The following is a description of a gene set: from publication Chen Y, Wang X (PMID 31504780) studied in species Mus musculus Mouse Gene Set: MIR_6925_5P Genes predicted to be targets of miRBase v22 microRNA mmu_miR_6925_5p in miRDB v6.0 with MirTarget v4 prediction scores > 80 (high confidence targets)., and this is the list of marker genes: Sec22c, Mup18, Hoxc4 (NCBI Gene Id 15423), Cpeb4 (NCBI Gene Id 67579), Atxn1l, Iqcm, Mup12, Tfcp2l1, Galnt3 (polypeptide N-acetylgalactosaminyltransferase 3), Stx3, Ms4a19, Snhg11, Jakmip1, Gimap1, Smtnl2, Tmeff2, Kcnma1, Arhgef11, Gins3, Rap1gap2, Slc35d1, Sh3glb1, B3galnt2, Rab6a, Hs2st1, Smo, Shisa5, Snapc1, Zfp768, Vdac3, Rap2c, Notch3, Pcdh1, Mup1, Prdm1, Mapk4, Dpf3 (NCBI Gene Id 97800), S2bpcox16, Taok2, 9230112D13Rik, Braf, Enox2, Mup20, Runx1t1, Mylk4, Otx1, Adarb1, Sypl2, Iqsec2, Mlf2, Mtmr3, Dop1b, Insr (insulin receptor), Dlg2, Capn1, Flywch1, Acacb, C5ar1, Syn1, Rnls, Rtl5 (retrotransposon Gag like 5), Gabbr1, Mup7, Anapc11, Trpm2, Kmt2d, Micos10, Vangl2, Necab3, Pou2f1, Stx17, Ino80e, Prpsap2, Gucy1b2, Hcn1, Bcat1, Cfap58, Vps39, Xylb, Fads3, Mpeg1, Rapgef2, Bcl6b, Ddx11, Paqr5, Lin7a, Ndst3, Relb, Chrm1, Plxna4, Apex2, Wnt1, Mllt6, Nav3, Dusp10, Necap1, Mup14, Cox16, Taf1, Zdhhc6, Polk, Osbpl3, Il7r, Creb3l3, Upp2, Lingo1, Spock2, Exoc6b, Rph3a, Wdr37, Fkbp6, Atoh8, Tmed7, Nme6, Trpm7, Siglecl2, Ptrhd1, Slc12a6, Cnnm4, Slc22a23, Mtss2, Stk32b, Gpm6b, Fchsd2, Mup8, Nr6a1, Tmem151a, Mup15, Tcl1, Kif18b, Tlcd5, St3gal1, Abhd3, Fbxw2, Ncbp3, Scrn3, Sptlc2, Gpd2, Cbln2 (NCBI Gene Id 225810), Med11, Nexn, Socs7, Mettl16, Cpt2, Bach2, Gm4922, Ganab (alpha glucosidase 2 alpha neutral subunit), Mobp, Fundc2, Wfikkn2, Txlnb, Mgat4c, Odf4, Plek, Aqp2, Tmem178b, Rabif, Col4a4, Atf6, Mtcl2, Serf2, Spsb4, Orc5, AU015228, Mup10, Mios, Sall4, Tnfsf4, Mlph, Grin2b, Gng2, Pcsk7, Lrrc2, Ankrd66, Ttc14, Plat, Hnf4a, Mup19 (major urinary protein 19), Ntrk3, Mgat3, M6pr, Sox6, Eny2, Mup16, Pafah1b2, Nav2, Hsf3, Zfp609, Pak3, Twist1, Gpr165, Rlig1, Runx2, Scn4a, Plekha3, Pcdhb17, Gtf2e1, Stard8, Uri1, Wdtc1, Negr1, Ikbkb (inhibitor of kappaB kinase beta), Fam107a, Anks1, Sbk3, Plcxd2, Selp, Neu3, Unc80, Shisa6, Mup9, Nt5e, Stx12, E2f3, Ulk3, Slc39a9, Pank1, Sar1a, Fto, Mmp25, Klhl14, Msx1, Irs1, Mup13, Itga9, Fam98a, Gid8, Igf2bp3, Pomk, Qpctl, Arl10, Trim67, Ppt1, Egr3, Sel1l, Stk10, Ankrd52, Clybl, Rgs20, Rbpms2, Ralgps1, Plcd4, Mtfr1l, Zfp518b, Ifi44, Zbtb42, 9930012K11Rik, Tal1, Foxb1, Jam2, Lmnb1, Cntn4, Nptx1, Atp6v0a2, Rbms3, Sec22b, Mef2d, Phactr2, Galnt6, Dhh, Ppp1r1c, Mnat1, Slc35f6, Speer4f1, Iqcc, Eif4g2 (eukaryotic translation initiation factor 4, gamma 2)